Given this list of marker genes MYOD1, ZNF143, LARP7, MEPCE, CC2D1A, here is a description of the gene set: Human Gene Set: GOBP_REGULATION_OF_SNRNA_TRANSCRIPTION_BY_RNA_POLYMERASE_II Any process that modulates the frequency, rate or extent of snRNA transcription mediated by RNA polymerase II. studied in species Homo sapiens